The following is a description of a gene set: species: Homo sapiens Human Gene Set: GOBP_GAMMA_AMINOBUTYRIC_ACID_TRANSPORT The directed movement of gamma-aminobutyric acid (GABA, 4-aminobutyrate), an amino acid which acts as a neurotransmitter in some organisms, into, out of or within a cell, or between cells, by means of some agent such as a transporter or pore., and this is the list of marker genes: SLC6A11, ABAT, TRH, APBA1, TRPC4, SLC6A6, SLC6A13, NTSR1, BEST1, SLC6A8, SLC32A1, CACNB4, SLC6A1, P2RX7, NF1, SLC7A14, SLC6A12, GABBR1, NHERF1